Given this list of marker genes Nnmt, Alkbh8, Dnmt3b, Prmt6, Trmo, Mettl21e, Prmt3, Suz12 (SUZ12 polycomb repressive complex 2 subunit), As3mt, Tmt1a2, Prdm14, Prdm4, Etfbkmt, Mettl14, Atpsckmt, Cad, Bhmt, Mgmt, Prdm1, Prmt1, Emg1, Dnmt3l, Coq3, Prdm16 (NCBI Gene Id 70673), Mtfmt, Trmt1, Ntmt1, Trmt112, Mettl4, Inmt, Mettl8, Ftcd, Tfb1m, Asmt, Cmtr2, Carm1, Ehmt2, N6amt1, Setd4, Prmt5, Setdb2, Spout1, Thumpd2, Tfb2m, Mettl6, Suv39h1, Setbp1, Nsd1, Rnmt, Smyd1, Trmt11 (tRNA methyltransferase 11), Kmt5b, Shmt2, Prmt2, Gatm, Setd7, Rrp8, Kmt5c, Tgs1, Mettl21c, Mettl21a, Suv39h2, Eef1akmt4, Prdm13, Lcmt2, Prdm10, Mrm2, Tarbp1, Mettl1, Bcdin3d, Setmar, Thumpd3, Trmt61a, Mettl3, Tmt1a3, Sirt7, Bmt2, Ezh2, Prmt7, Wdr5, Setd2, Kmt2b (lysine (K)-specific methyltransferase 2B), Trmt44, Mepce, Jarid2, Nsun2, Prdm12, Nop2, Pemt, Mettl25, Ftsj1, Trmt10a, Pcmt1, Setdb1, Setd1a, Prdm6, Fbll1, Gamt, Gcsh (NCBI Gene Id 68413), Mrm1, Tyms, Mrm3, Bhmt2, Smyd3, Mecom, Shmt1, Dnmt1, Eef1akmt3, Nsun7 (NCBI Gene Id 70918), Prdm11, Eef1ece2, Comt, Nsd3, Mettl23, Prdm9, Dnmt3a, Tmt1b, Mettl16, Prmt8 (NCBI Gene Id 381813), Pcmtd1, Henmt1, Wdr4, Pnmt, Fbxo11, Fdxacb1, Camkmt, Setd3, Nsun5, Trmt13, Antkmt, Smyd2, Smyd4, Mettl2, Pcmtd2, Eef2kmt, Eef1akmt1, Gart, Nsun3, Mettl17, Setd5, Mettl24, Setd1b, Icmt, Trmt2a, Nsd2, Dot1l, Comtd1, Carnmt1, Trmt1l, Mettl13, Fbl, Fam98b, Trmt12, Bhmt1b, Ndufaf7, Trmt9b, Ezh1 (enhancer of zeste 1 polycomb repressive complex 2 subunit), Setd6, Trmt10c, Hemk1, 2700097O09Rik, Nsun4, Ehmt1, Amt, Gnmt, Mtr, Ntmt2, Trmt10b, Prdm15, Eef1akmt2, Kmt2d, Kmt2e (lysine (K)-specific methyltransferase 2E), Kmt5a, Ash1l, Kmt2c, Pcif1, Prdm5, Mettl22, Ndufaf5, Ash2l, Tomt, Trmt2b, Prdm8, Nsun6, Otc, Tyw3, Trdmt1, Zcchc4, Fam98a, Armt1, Bud23, Dimt1, Tpmt, Mettl18, Ftsj3, Cmtr1, Kmt2a (NCBI Gene Id 214162), Atic, Tmt1a, Smyd5, Dph5, Prmt9, Mettl15, Hnmt (histamine N-methyltransferase), Lcmt1, Mettl5, Vcpkmt, Mettl9, Coq5, Trmt5, here is a description of the gene set: Mouse Gene Set: GOMF_TRANSFERASE_ACTIVITY_TRANSFERRING_ONE_CARBON_GROUPS Catalysis of the transfer of a one-carbon group from one compound (donor) to another (acceptor). studied in species Mus musculus